Given this list of marker genes ZNF280D, NAAA, AGA, CRYBA1, ALDH1A3, FAM83B, NRARP, ANP32E, GLCCI1, here is a description of the gene set: Human Gene Set: MIR487B_3P Genes predicted to be targets of miRBase v22 microRNA hsa-miR-487b-3p in miRDB v6.0 with MirTarget v4 prediction scores > 80 (high confidence targets). from publication Chen Y, Wang X (PMID 31504780) studied in species Homo sapiens